The following is a description of a gene set: species: Mus musculus Mouse Gene Set: chr11A3, and this is the list of marker genes: Gm12093, Gm12059, Vps54, Gm12070, Aftph, Ppp4r3b, Rpsa-ps3, Mir216a, Mir217, Gm12071, Mir216c, Gm12030, 4933427E13Rik, Gm23514, Gm12022, C1d, Gm24850, Glns-ps1, Gm12056, Ahsa2, 2900018N21Rik, Mtif2, Gm24917, Sanbr (SANT and BTB domain regulator of CSR), Gm12029, 1700093K21Rik (RIKEN cDNA 1700093K21 gene), Rpl12-ps2, Pgam1-ps1, Mir6372, Rel (NCBI Gene Id 19696), Gm23386, Gm6685, Gm12041, Gm12047, Etaa1os, Wdpcp, Pex13, Gm12089, Lgalsl, A830031A19Rik, Cct4, Sertad2, Fancl, Gm12015, Gm12095, Rpl15-ps1, 8430419K02Rik, Commd1, Gm12046, Gm12061, Gm12665, Gm12069, Gm10466, 9130230N09Rik, Gm12019, Gm22588, Mdh1, 4930538E20Rik, Gm24398, Pnpt1, 1700030C12Rik, Gm12068, Gm22807, Gm12035, Gm22753, Gm12085, 2610001A08Rik, Xpo1, Rpsa-ps5, Mir216b, Tmem17, Gm12074, Gm12063, Gm12080, Sptbn1, Prorsd1, Ugp2, Vrk2, 5730522E02Rik, Gm12040, Selenok-ps1, Gm12027, Efemp1, Gm26253, Gm12031, Gm12087, Meis1, Gm12038, Gm12017, Gm24255, Gm12024, Rtn4, 4932414J04Rik, B3gnt2, Gm12072, Gm23109, Gm12058, Gm12021, Gm12092, Gm12033, 1700061J23Rik, Gm28401, Gm12045, Gm12052, Etaa1, Mir1933, Ccdc88a, Fem1al, Gm12034, Gm12077, Gm12057, Ehbp1, Ccdc85a, Gm23093, Actr2, Gm12018, Cfap36, Fam161a, Spred2, Otx1, Gm8098, Gm6899, Gm12091 (NCBI Gene Id 674963), Gm23582, Gm12090, Gm3810, Usp34, 4933430M04Rik (NCBI Gene Id 71316), Gm16141, A630052C17Rik (RIKEN cDNA A630052C17 gene), Papolg (poly(A) polymerase gamma), Cep68, Rab1a, Slc1a4, Gm12026, Gm12073, 2610024D14Rik, Pus10, Gm12020, Gm23021, Eml6, Peli1, Bcl11a, Rps27a, 2810471M01Rik, Clhc1, Gm12067, Gm12094